The following is a description of a gene set: A homeostatic process involved in the maintenance of a steady state level of glucose within a cell. studied in species Mus musculus Mouse Gene Set: GOBP_INTRACELLULAR_GLUCOSE_HOMEOSTASIS, and this is the list of marker genes: Cacna1d, Klf15, Lepr (leptin receptor), Pik3r1 (NCBI Gene Id 328326), Birc5 (baculoviral IAP repeat-containing 5), Irs2, Nox4, Ppard, Smad2, Brsk2, Gpr27, Slc39a14, Gcg, Kcnj11, Kif5b, Bad, Unc13b, Lrrc8a, Grk2, Crh, Selenot, Abca12, Neurod1, Twnk, Mir130a, Adcy5, Foxo3, Mir192, Foxk2, Tbc1d1, Apoc3, Ptprn, Igf1, Usf2, Ngfr, Adcy8, Col1a1, Ogt, Smarca4, Hnf1a, Osbp, Gpx1, Mir320, Oprk1, Ager, Arrb1, Ptpmt1, Gclm, Ppp3cb, Tgfb1, Atg7, Nr1h4, Ccdc186, Hmgcr, Mup1, Slc2a2, Tra2b (NCBI Gene Id 52560), Smad4, Map4k4, Hkdc1, Pck1, Efna5, Klf7, Ccl2, Socs6 (suppressor of cytokine signaling 6), Gper1, Rbm4, Hk1, Sox4, Ptprn2, Mpc2 (mitochondrial pyruvate carrier 2), Foxk1, Slc9b2, Ppp3ca, Slc12a6, Hcfc1, Cpb2, Hk2, Prkaa2, Raf1, Mup11, Adra2a, Rfx6, Trpa1, Mup2, Hk3, Gclc, Prkaca, Sidt2, Slc12a7, Dynll1, Cltrn, Prkn, Smarcb1, Slc29a1, Icam1, Srf, Gprc6a, Zbtb20, Sri, Alms1, Ucp2, Sin3a, Tiam1, Nucks1 (nuclear casein kinase and cyclin-dependent kinase substrate 1), Fkbp1b, Fto, Ins1, Hmgn3, Ern1, Ranbp2, Mup4, Oxct1, Cacna1e, Foxa2, Tunar, Cdk16, Ang2, Cartpt, Mir532, Crhr2, Usf1, Vcam1 (NCBI Gene Id 22329), Jagn1, Tcf7l2, C1qtnf12 (C1q and tumor necrosis factor related 12), Camk2n1, Gpr39, Smad3, Hif1a, Gpr68, Pde4c, Lrp1, Tjp1, Foxa3, Pde3b, Rab11fip2, Cyp7a1, Fcor, Aqp4, Eny2, Rab34, Prkce, Mir200a, C2cd2l (C2 calcium-dependent domain containing 2-like), Myh9, Mir410, Mir337, Myt1, Ano1, Abcc8, Mup3, Nadk, Gckr, Lrrc8d, Mir27a, Mir369 (microRNA 369), Pax2, Mup5, Ndufaf2, Aacs, Abcg1, Rab11fip5, Endog, Baiap3, Epha5, Casr, Lrp5, Gas6 (growth arrest specific 6), Stx4a, Ncoa6, Igf1r, Stxbp4, Gpld1, Kcnb1, Serpinf1, Sybu, Nr1d1, Cftr, Pde8b, Pih1d1, Stxbp3, Star, Gck, Vsnl1, Rab11b, Rptor, Kat5, Pik3r2, Piwil4, Zbed6, Ace, Pde1c, Lin28a, Prkaa1, Pla2g6, Mlxipl, Xbp1, Trpm4, Pck2, Th, Rack1, Trpm5, Ghrl, Pax6, Agt, Mir379, Sirt1, Pdx1, Gjb6, Pim3, Trem2, Pik3ca, Rac1, Nptx1